Given this list of marker genes Hus1b, Rad9a, Hus1, Rad9b, Rad1, here is a description of the gene set: species: Mus musculus Mouse Gene Set: GOCC_CHECKPOINT_CLAMP_COMPLEX Conserved heterotrimeric complex of PCNA-like proteins that is loaded onto DNA at sites of DNA damage.